Given this list of marker genes COL1A2, ITPA, CANX, FASN, BPTF, COL1A1, VPS13B, NOTCH3, COX7B, SPEN, KPNA6, UBAC1, TMPO, DHPS, AKAP8, PRMT1, PCNT, CDK2AP1, GPN1, BIRC5, ARPP19, HNRNPAB, RBM42, FAM98A, NDUFA1, CAND1, GPI, HOXA2, MSX2, NHP2, URI1, HNRNPU, PFDN6, COX7A2L (NCBI Gene Id 9167), RAB5C, SRGAP2, TMEM147, POM121, ETV2, ZFC3H1, UPK1A, PTTG1, TENT4A, APLNR, TDG, CHD2, RALGPS1, CENPX, MAD2L1, UPF2, COX6B1, TRIM37, VAV2, P4HB, SNRPF, FBLN2, STIL, EIF4E2, NUP62, LMNB1, WDR37, UBN1, PSEN2, NSUN5P1, ELF4, EIF3K, here is a description of the gene set: Up-regulated genes in metastatic vs primary solid tumors. studied in species Homo sapiens Human Gene Set: RAMASWAMY_METASTASIS_UP from publication Ramaswamy S, Ross KN, Lander ES, Golub TR (PMID 12469122) Metastasis is the principal event leading to death in individuals with cancer, yet its molecular basis is poorly understood. To explore the molecular differences between human primary tumors and metastases, we compared the gene-expression profiles of adenocarcinoma metastases of multiple tumor types to unmatched primary adenocarcinomas. We found a gene-expression signature that distinguished primary from metastatic adenocarcinomas. More notably, we found that a subset of primary tumors resembled metastatic tumors with respect to this gene-expression signature. We confirmed this finding by applying the expression signature to data on 279 primary solid tumors of diverse types. We found that solid tumors carrying the gene-expression signature were most likely to be associated with metastasis and poor clinical outcome (P < 0.03). These results suggest that the metastatic potential of human tumors is encoded in the bulk of a primary tumor, thus challenging the notion that metastases arise from rare cells within a primary tumor that have the ability to metastasize.